The following is a description of a gene set: The distal and proximal transverse palmar creases are merged into a single transverse palmar crease. studied in species Homo sapiens Single transverse palmar crease Human Gene Set: HP_SINGLE_TRANSVERSE_PALMAR_CREASE, and this is the list of marker genes: CSNK2A1, GJA8, U2AF2, B3GLCT, SMPD4, POLR1A, ZNF462, TAF6, PEX6, CSGALNACT1, CCNQ, EP300, TPM2, RPS6KA3, RNU4ATAC, RPS23, ANKRD11, SMOC1, EXT1, FLNA, RPL10, TCF12, MSL3, KAT6B, NXN, ZFX, MAP1B, CREBBP, BRF1, KMT2D, CTBP1, TMEM147, CHST3, STXBP1, NBAS, UBE3B, PEX12, KATNB1, MED25, G6PC3, MEG3, ARID1B, LIFR, COG1, CDK10, PEX13, NECTIN1, SMAD2, NALCN, NAA20, PPP2CA, TRPS1, BHLHA9 (basic helix-loop-helix family member a9), FOXP1, TRIM37, TBX4 (T-box transcription factor 4), NUP107, CD96, CEP57 (NCBI Gene Id 9702), UBR7, GLE1, ESCO2, LETM1, KCNK9, FGF9, TCF4, POLRMT, MEGF8, FGFRL1, KDM6A, ADNP, RAD21, ATP6V1A, BICD2, DPH1, PUF60, EBF3, PEPD, PEX3 (NCBI Gene Id 8504), THOC2, PKDCC, SPTBN1, AHDC1, MCTP2, TSEN34, PEX26, ATR, PIEZO2, FBXO28, HDAC4, HCCS, FILIP1, TOE1, B4GALT7, NUP188, NSD2, MAP3K7, TBX5, MED12, SLC25A12, UFC1, VAC14, GDF5, RERE, VPS51, ARL3, PEX19, H4C9, PEX14, RBM10, TBCK, TWIST1, TRIM8, JARID2 (jumonji and AT-rich interaction domain containing 2), PIGS, FGFR3, ZMYM2, TGDS, RNU4-2, DLK1, ITCH, TRIO, SMC1A, LTBP4, RTL1, DDX11, BMP4, PEX11B (NCBI Gene Id 8799), EXTL3, XYLT1, PEX5, SMC3, GJA5 (gap junction protein alpha 5), NIPBL, FBXO11, MEF2C, CEP55, ZNF292, ROR2, GNB2, FGD1, EZH2, FIG4, DPH2, CILK1, CDK19, COX7B (cytochrome c oxidase subunit 7B), IFT57, DLX4, RAB11B, DIS3L2, PDHA1, GLYCTK, CKAP2L, CPLX1, SMARCAD1, SETBP1, VPS13B, BMPR1B, DPAGT1, TELO2, PEX1, PTPRF, TFAP2A, SET, APC, PEX10, TNNI2, DHX30, PPP3CA, GRIN1, PEX2, H3-3A, TNNT3, LMX1B, KDM4B, TSEN2, AFF3, ALDH6A1, RIN2, PPP2R3C, SMARCA2, IFT43, HDAC8, PEX16, SPRTN, UBR1, TASP1 (taspase 1), MTFMT, WAC, PACS1, TSEN15, SMC5, DOCK6, NSDHL, STAG1, LONP1, NEXMIF, CTCF, NGLY1, CDC42BPB, BRD4, IFT122, PNPLA6, NDUFB11, SMS, SEPSECS, PLAA, IGF1, MYH3 (NCBI Gene Id 4621), FGFR2, TAF4, DEPDC5, COX14, EHMT1, CLCN7, NOG, TSEN54, CCBE1